Given this list of marker genes ATG3, GABARAPL1, RB1CC1, WIPI2, WDR45, WDR45B, GAA, ATG2A, STBD1 (NCBI Gene Id 8987), ATG2B, ATG12, WIPI1, here is a description of the gene set: studied in species Homo sapiens The selective degradation of glycogen by macroautophagy. Human Gene Set: GOBP_GLYCOPHAGY